Given this list of marker genes RUNX2, GLI3, BTRC, KIF7, KCTD6, ULK3, PRKACA, HERC4, PTCH1, GPR161, MGRN1, RB1, TRAF3IP1, HHIP, GPC3, TULP3, SERPINE2, IFT172, PTCH2, GPR37L1, VCP, ENPP1, KCTD21, CD3E, IFT122, UBR5, MEGF8, RACK1, PRKACB, RFX4, GLIS2, KCTD11, SUFU, MOSMO, NCOA2, TMED2, CDK20, here is a description of the gene set: Human Gene Set: GOBP_NEGATIVE_REGULATION_OF_SMOOTHENED_SIGNALING_PATHWAY studied in species Homo sapiens Any process that stops, prevents, or reduces the frequency, rate or extent of smoothened signaling.